Given this list of marker genes Spo11, Terb1, Majin, Fancd2, 4930447C04Rik, Rad51c, Cntd1, Trip13, Cenps, Mlh1, Msh4, Tex19.1, Rad54b, Nbn, Bard1, Ccnb1ip1, Chtf18, Rmi1, Slx4, Hsf2bp, Cep63 (NCBI Gene Id 28135), Ercc4, Sycp3 (synaptonemal complex protein 3), Mnd1, Psmc3ip, Eme2, Rnf212, Top6bl, Rbbp8, Brca1, Rad51, Rad54l, Fancm, Hfm1, Top2a, Rad51ap1, Ube2b, Mus81, Rad50, Topbp1, Top2b, Msh5, Meiob, Eme1, Sycp1, Dmc1, Rnf212b, Syce3, Cenpx, Prdm9, Brip1, Rad51d, Ankrd31, Brme1, Tex11, Mre11a, 1700028K03Rik, Ankle1, Mcmdc2, Hdac10, Shoc1, Morc2b, Ubr2, Terb2, here is a description of the gene set: Mouse Gene Set: GOBP_HOMOLOGOUS_RECOMBINATION A DNA recombination process that results in the exchange of an equal amount of genetic material between highly homologous DNA molecules. studied in species Mus musculus